Given this list of marker genes SRF, APP, NFIB (nuclear factor I B), TGFB1, VEGFA, PPARA, TENT2, YY1, RARA, NFATC3, PDGFB, BMP4, NCOR1, REST, RELA, QKI, TWIST1, ZNF512B (zinc finger protein 512B), NFATC4, SOX9, TNF, HIF1A, PPARG, SMAD3, LILRB4, ESR1, POU5F1, PPARD, NCOR2, here is a description of the gene set: Human Gene Set: GOBP_NEGATIVE_REGULATION_OF_MIRNA_METABOLIC_PROCESS studied in species Homo sapiens Any process that stops, prevents or reduces the frequency, rate or extent of miRNA metabolic process.